Given this list of marker genes PLK2, CNOT6L, TNKS1BP1, CNOT4, CDC25C, CNOT7, NPM1, CNOT9, CNOT6, TP53, PLK3, PLAGL1, CNOT2, CNOT1, BTG2, RGCC, CPAP, CNOT11, CNOT3, CNOT8, CNOT10, here is a description of the gene set: part of: TP53 Regulates Transcription of Cell Cycle Genes BTG2 is induced by TP53, leading to cessation of cellular proliferation. BTG2 binds to the CCR4-NOT complex and promotes mRNA deadenylation activity of this complex. Interaction between BTG2 and CCR4-NOT is needed for the antiproliferative activity of BTG2, but the underlying mechanism has not been elucidated. Two polo-like kinases, PLK2 and PLK3, are direct transcriptional targets of TP53. TP53-mediated induction of PLK2 may be important for prevention of mitotic catastrophe after spindle damage. PLK2 is involved in the regulation of centrosome duplication through phosphorylation of centrosome-related proteins CENPJ and NPM1. PLK2 is frequently transcriptionally silenced through promoter methylation in B-cell malignancies. Induction of PLK3 transcription by TP53 may be important for coordination of M phase events through PLK3-mediated nuclear accumulation of CDC25C. RGCC is induced by TP53 and implicated in cell cycle regulation, possibly through its association with PLK1. PLAGL1 (ZAC1) is a zinc finger protein directly transcriptionally induced by TP53. PLAGL1 expression is frequently lost in cancer and PLAGL1 has been implicated in both cell cycle arrest and apoptosis, but its mechanism of action remains unknown. Reactome Pathway: TP53 regulates transcription of additional cell cycle genes whose exact role in the p53 pathway remain uncertain studied in species Homo sapiens